Given this list of marker genes Fth1, Fcer2a, Fau, Cox7a2l, Uba52, Cxcr4, Trim7, Txnip, here is a description of the gene set: species: Mus musculus Genes negatively differentially expressed in cell type: B cell upon treatment with cytokine: IL-21 in mouse lymph nodes in vivo. Cytokines mediate cell-cell communication in the immune system and represent important therapeutic targets. A myriad of studies have highlighted their central role in immune function, yet we lack a global view of the cellular responses of each immune cell type to each cytokine. To address this gap, the authors created the Immune Dictionary, a compendium of single-cell transcriptomic profiles of more than 17 immune cell types in response to each of 86 cytokines (>1,400 cytokine-cell type combinations) in mouse lymph nodes in vivo. A cytokine-centric view of the dictionary revealed that most cytokines induce highly cell-type-specific responses. For example, the inflammatory cytokine interleukin-1β induces distinct gene programmes in almost every cell type. A cell-type-centric view of the dictionary identified more than 66 cytokine-driven cellular polarization states across immune cell types, including previously uncharacterized states such as an interleukin-18-induced polyfunctional natural killer cell state. Mouse Gene Set: CUI_B_CELL_IL21_RESPONSE_DN from publication Cui A, Huang T, Li S, Ma A, Pérez JL, Sander C, Keskin DB, Wu CJ, Fraenkel E, Hacohen N (PMID 38057668)